The following is a description of a gene set: species: Homo sapiens Human Gene Set: MIR450A_1_3P from publication Chen Y, Wang X (PMID 31504780) Genes predicted to be targets of miRBase v22 microRNA hsa-miR-450a-1-3p in miRDB v6.0 with MirTarget v4 prediction scores > 80 (high confidence targets)., and this is the list of marker genes: MTCL2, BNC2, TM9SF3, GTF3C2 (general transcription factor IIIC subunit 2), CT45A1, STAT1, SEPTIN3, RPA3, UBE2F, MBNL3, RPL15, SLCO1A2, CENPQ, PKIB, DGKH, SPRR4, ZMYND11, GPRASP3, PABPC1L, IRAK3, ZNF502, MEF2C, RBBP4, SH3TC2, ZMYM4, MIER1, ROCK2, STAC, GRM6, COBL, PRRX1, CIPC, ZNF280C, GPBP1L1, SDHD, DCBLD2, TMEM170B, TRMT10C, ENY2, ABLIM1, PRPF3, FBXO33, HERC3, GPATCH2, SPRTN, REEP5, CNGB3, CNTNAP2 (NCBI Gene Id 26047), ZNF365, PLEKHS1, TMEM41A, MEX3C, ULBP2, MTRF1L, FBXO4, PPM1L, ZEB1, FGA, FAM53C, RNPEP, CDH2 (NCBI Gene Id 1000), MRPS27, SARAF, NSD1, PRKACB, SRA1, RIF1, CHD9, POM121, ZNF704, BEND2, VWC2 (von Willebrand factor C domain containing 2), HNRNPA3, AFF1, ARHGEF18, MYEF2, TXLNB, UHMK1, CT45A10, AAK1, TRPS1, PFKFB2, QNG1, ZNF662, LRRC51, IL20RA (NCBI Gene Id 53832), PHF2, HSPA9, PCSK7, BCAP29, CT45A9, MRE11, ARSB, RASSF10 (NCBI Gene Id 644943), CT45A5, FGF18, NSL1, CRNKL1, RFX3, BMP2, CHST4, ADRA1A, TRIO, DENND5A, RFTN2, UBE3C, SLC49A4, AK9, PSIP1, JADE3, ZNF264, PIGN, CREBL2, MTHFD2, FOXN2, HACD4 (3-hydroxyacyl-CoA dehydratase 4), MAP7D2, ALKBH5, CTDSPL2, MBOAT7, SFRP1, PLA2G4D, VCL, ELMO1, GPR158, NAPG, TTC22, STAP1, SCP2, SGIP1, DCLK3 (doublecortin like kinase 3), ELAPOR1, ZNF578, NFIA, NUDT19, SMAD2, ANKDD1A, DNAJC12, HMGCR, MKRN1, SF3B4, SLC34A2, GTF2H3, MIS18BP1, CYBRD1, ANK3, SUSD4, CBLL1, HMGN5, OLFML1, MMP20, GRAMD1B, WBP1L, GRPEL1, OSBP, KLF4, PTN, KLHL8, GUCY1A2, CYSLTR1, ABCF3, CXCL9, LMBRD2, SLC35E2A, CTDSP2, MAP3K7, VSNL1, ROR1, GPC6, EPS8L3, SLC12A8, MYO5B, POM121C, OPRK1, STMN4, CRIPTO, GVQW3, FRMPD4, HPRT1, POU2F1, AIRIM, HAUS5, BBX, GKN2, CADPS2, GULP1 (NCBI Gene Id 51454), SYNPO2, CDS2, PHF20, NIPAL1, RASGEF1A, ONECUT2, OCRL, NEFH